Given this list of marker genes Rbp7 (NCBI Gene Id 80531), Rbp4, Adh7, Rbp1, Crabp2, Crabp1, Stra6, C8g, Lrat, Rbp3, Rlbp1, Adh4, Cyp2w1, Rbp2, here is a description of the gene set: Mouse Gene Set: GOMF_RETINOL_BINDING Binding to retinol, vitamin A1, 2,6,6-trimethyl-1-(9'-hydroxy-3',7'-dimethylnona-1',3',5',7'-tetraenyl)cyclohex-1-ene, one of the three components that makes up vitamin A. Retinol is an intermediate in the vision cycle and it also plays a role in growth and differentiation. species: Mus musculus